The following is a description of a gene set: from publication Chen Y, Wang X (PMID 31504780) Genes predicted to be targets of miRBase v22 microRNA hsa-miR-577 in miRDB v6.0 with MirTarget v4 prediction scores > 80 (high confidence targets). studied in species Homo sapiens Human Gene Set: MIR577, and this is the list of marker genes: ESCO1, SP3, SLC13A1, SGCD, TFAP2A, AHR, ZMPSTE24, HOOK3, DNAJB11, EPC1, LMO3, TNKS2, ZMIZ1, AGK, TMOD2, TLN2, IGSF11, RANBP3L, SLC2A14, NUDT15, VDAC1, MMGT1, DIP2B (NCBI Gene Id 57609), LRP12, TFAP2B, DNAJB9, SOX9, NDUFB4, ERC2, CCR2, TESC, USP6NL, CDK13, ZNF546, MRO, LHFPL3, SLC27A6, CDK19, DENND6A, ING1, STAG2, ZNF235, CYBRD1, CTSC, MCHR2, SYT16, SPIN3, ZBTB43, FKBP1A, TFPI2, RPS6KA3, SPAG9, SERPINB9, SAMHD1, ADAMTS3, IPMK, IGF2BP1, TXNDC8, GFPT1, CD44, ADAMTSL3, TBC1D8B, NEK11, B3GALNT2, ENSG00000255537, PATE3, BMPR2 (bone morphogenetic protein receptor type 2), LYPD6, EXTL2, CLIC4, CFAP20, PABPC4L, FUT11, ZFPM2, SLU7, ZMAT3, ZNF827, ZBTB4, CREBL2, PCDHB10, KCNJ10, ZEB2, LRRTM3, CHFR, SIKE1, SKI, AIP, SPDYE5, IFT70A, CSRNP2, CTDSPL2, SP4, IFNA1 (interferon alpha 1), DNAJC16, SLC7A11, ZFHX3 (zinc finger homeobox 3), RORA, PLEKHA1, IKZF2, SKP2, RBM12, SDC2, ADRA1A, SHROOM2, PTF1A (pancreas associated transcription factor 1a), DGKI, BTAF1, CISD2, PELI1, GALNT3, C18orf54, KCNA4, USP25, TMEM53, SPDYE3, DAZ4, SIMC1, CLMN, EPHA5, TMEM61, PGGT1B, KITLG, FBXO36, PLXDC1, JCAD, KCNJ13, TNFSF8, POLH, PPM1H, RNF217, SH3GL2, TMEM167A, GUCY1A2, CASD1, ADSS2, ITGB8, NCKAP5, HOXA1, SLC10A7, CCR6, DENND2A, KLHL24, PPP1R3B, TMEM98, VGLL3, S100Z, ETNK1, JAGN1, PXDC1, TVP23C, UMAD1, OSR2, CLDN1, CREB1, ZNF711 (zinc finger protein 711), IRAK1BP1, SALL4, CCDC125, RHOA, GIN1, FZD1, MINDY2, STYK1, AQP4, CCDC82, GRIK4, MRPL19, CCNE2, TASOR, ZNF776, MRPS10, DENND1B, WEE2, ZYG11A (NCBI Gene Id 440590), LRRFIP2, GLB1L3, ZNF101, SPDYE1, KPNA1, RSBN1 (round spermatid basic protein 1), GSE1, LARP6 (La ribonucleoprotein 6, translational regulator), PARP1, KLF4 (KLF transcription factor 4), PAWR, CMTM7, CCDC39, ZDHHC15, CALCRL, TENM1 (NCBI Gene Id 10405), SRSF1, ZC2HC1A, FRMPD4, NEIL2, HAUS6, KAT6A, SDK1, LSM14A, PLCL1, ZBTB11, RDX (NCBI Gene Id 5962), PRDM12, BRWD3, NEK6, SPDYE6, PCLO, HPSE, TRPC1, RNF149, KRTAP4-4, SERTAD3, BHLHE40, UXS1, EIF2AK4, MAFF, CYP2J2 (cytochrome P450 family 2 subfamily J member 2), LIG4, N4BP2L2, MLLT11, EEA1, UNKL, MRPS18C, PAPOLA, ZNF334, PCDHB11, PHC3, DAZ2, PCSK5, MYNN, ARHGAP42, HAT1, EFHC2, KLHL2, PUM2, DACH1, IGF1R, SSBP2, MTF1, PCMTD1, RBP4, FAM120C, ANTXR2, CDKL3, RBFOX1, KRTAP1-5, PGRMC1 (progesterone receptor membrane component 1), SEMA5A, DAZ1, RTN4RL2, ZNF280D, TULP4, PCNX1, CRHR1, RLIM, SOWAHA, FAM107B, PPTC7, AMER2, GARIN1B, FBXW10B, ODF2L, PARS2, TAGAP, F2R, HNRNPU, NEK1, SMURF2, SLC22A24 (NCBI Gene Id 283238), SPTBN1, GRIA4, SCN9A, HP1BP3, CNOT11, CREB5, ARL15, PEX13, SLIT3 (NCBI Gene Id 6586), SYCP2, DPP10, TCFL5, FGG, DAZ3, PRTG, CCPG1, RAB3IP, EMC1, GPR65, SHMT2 (NCBI Gene Id 6472), EPM2AIP1, C5, VPS13C, FAM135A, ARID2 (NCBI Gene Id 57676), INO80D, FOXK1, SLC30A8, HDX (highly divergent homeobox), GRM7, ZCCHC10, BLZF1, APLN, UGT3A1, UBR2, PRKAA2, GOLPH3, MRPL33, DNAJC21, GXYLT1, PPP6C, BAZ2A, DCX, HCFC2, ULK2, EPDR1, CYB5R4, TM9SF3, NRXN1, RBMS3, GRIN2A, SCRT2, LACTB2, TRHDE, TAF7L, PCDH20, ZNF655, PABIR3, DIPK2A, CAV1, GKN2, KLF12, UGT2A3, ZSCAN2, BPTF, PIWIL1, HEBP2, SETD5, TXLNG